Given this list of marker genes RSPH6A, RSPH14, CFAP119, ROPN1L, IQUB, DYDC1, RSPH4A, CFAP206, DNAJB13, RSPH1, CFAP91, NME5, CFAP251, CFAP61, RSPH9, RSPH3, here is a description of the gene set: species: Homo sapiens Human Gene Set: GOCC_RADIAL_SPOKE Protein complex that links the outer microtubule doublet of a 9+2 type ciliary or flagellar axoneme with the sheath that surrounds the central pair of microtubules. Composed of a stalk that attaches to each doublet microtubule and a globular structure (spoke head) that projects toward the central pair of microtubules.